The following is a description of a gene set: studied in species Mus musculus Any complex that possesses ubiquitin conjugating enzyme activity. Mouse Gene Set: GOCC_UBIQUITIN_CONJUGATING_ENZYME_COMPLEX, and this is the list of marker genes: Rnf40, Ube2a, Ube2v2, Stub1, Rnf20, Ube2b, Ube2v1, Ube2n